The following is a description of a gene set: Human Gene Set: GOBP_REGULATION_OF_SYNAPTIC_TRANSMISSION_GLUTAMATERGIC Any process that modulates the frequency, rate or extent of glutamatergic synaptic transmission, the process of communication from a neuron to another neuron across a synapse using the neurotransmitter glutamate. species: Homo sapiens, and this is the list of marker genes: CDK5, TNR, PLPPR4, ADORA1, TPRG1L, HTR2A, STXBP1, NPS, GRIK1, TSHZ3, MEF2C, PRKN, NLGN3, GRIN2D, NTRK1, SHANK3, TNF, GRM5, HOMER1, CACNG2, HDAC6, GRM7, SERPINE2, UNC13A, NLGN2, GRIN2C, NLGN1, CACNG4, CACNG5, RNF167, ATAD1, CLN3, ADORA2A, GRM4, GRM3, CACNG8, GRIN1, SYT1, KMO, DRD3, DTNBP1, CACNG3, GRM2, FXR1, GRM1, GRM8, CACNG7 (NCBI Gene Id 59284, calcium voltage-gated channel auxiliary subunit gamma 7), GRIN2B, DRD1 (dopamine receptor D1), SLC38A2, OPHN1 (NCBI Gene Id 4983), GRIN2A, DRD2, HCN1, IQSEC2, PTK2B, MAPK8IP2, CCR2, GRM6, NRXN1, RELN, MIR142, GRIK3, FRRS1L, UCN, CCL2, ATP1A2, PSEN1, RAB3GAP1, DISC1, DKK1, LRRK2, GRIK2, NPY2R (neuropeptide Y receptor Y2)